Given this list of marker genes IRF4, DPP4, C12orf56, GAB3, FURIN, TCP1, SEC23B, RGS1 (regulator of G protein signaling 1), BATF, NCOA3, SPINT2, VDR, IMMT, RRAGD, RPS6KB2, RAB30 (NCBI Gene Id 27314), CYTH1, TSPAN5, BHLHE40, HERC1, MIR21, EOMES, MKRN1, LRRC59, LIMA1, CTLA4, IL9, ATXN1, SMARCAL1, ETNK1, TBC1D1, TESPA1, ABHD4, STK4, FCHSD2, CD5, ANKRD44, RASL11A, SEMA4D, NIPAL2, DMAC2, HPGD, IL2RA, KPNA6, RAB19, FGFR1OP2, GAB2, HSPH1, CREB3, TIAM1, TRAFD1, PGM3, NFKBIZ, IL5, HSPA13, AP4B1, RASGRP3, RGS16, MAPK1, RNF125, IL13, BCL2, EEIG2, TXNDC16, MEOX1, SLC9A7, STK17B, SSNA1, H2BC21, ADAM19, LRIG1, RASAL3, PLXDC1, XPOT, PTPN9, FAM98A, DARS1, SYTL3, HIPK1, GPCPD1, MAN2A2, ASAP1, CD69, PRPF38B, ETS1, GIT2, SNORA52, DHRS3, ITK, CERS6, GNG2, BTG1, NABP1, TMEM71, KRT1, EAF1, NIT1, CD200R1, IER5, H2AJ, ELL2, GFI1, FYN, RASSF5, TBC1D13, CYLD, IKZF2, ACTN4, TBC1D20, NBEAL2 (NCBI Gene Id 23218, neurobeachin like 2), RAB27B, FAM50A, H2AC21, CYC1, TNF, TNFSF8, RNF168, CDH1, CASP3, SGSH, GNPDA1, LRRC32, DUSP4, PHF20L1, IKZF4, LPAL2, PRKCQ, CISH, SMAP2, CSF1, CSRP1, MGAT2 (alpha-1,6-mannosyl-glycoprotein 2-beta-N-acetylglucosaminyltransferase), YWHAQP8, DIPK1A, SEMA5A, ARHGAP25, TUT7, LCP2, GLDC, CEP164, RAP1A, BCL6, SLCO3A1, SLC39A8 (solute carrier family 39 member 8), PTPN1, CNKSR2, CD84 (NCBI Gene Id 8832), XBP1, NSMCE1, PGM1, SNORA70E, RASA1, TRIP10, REL, TPD52L2, IL17RB, RRM1, ACD, HIPK2, CD44 (NCBI Gene Id 960), PTGER2, LRFN2, MAP4K1, GPR132, HDAC9, SLC37A3, BCL11B, POLR2E, P4HB, BCL2L1, MAL, ST8SIA4, CXCL13, CAMK2D, CXCR4, UNC13D, ETV3, SOCS1, SLC12A2, GDI1, CD46, PITRM1, NMT1, TIGIT, C12orf76, MRPL35, PTGDR, PECAM1, TNFRSF9, NDFIP2, CDCA7L, EDARADD, PCED1B, SLC26A11, PDE4B, TTC39B (NCBI Gene Id 158219), JOSD1 (NCBI Gene Id 9929), IGSF11, STAT4, here is a description of the gene set: STAT3, an essential transcription factor with pleiotropic functions, plays critical roles in the pathogenesis of autoimmunity. Despite recent data linking STAT3 with inflammatory bowel disease, exactly how it contributes to chronic intestinal inflammation is not known. Using a T cell transfer model of colitis we found that STAT3 expression in T cells was essential for the induction of both colitis and systemic inflammation. STAT3 was critical in modulating the balance of T helper 17 (Th17) and regulatory T (Treg) cells, as well as in promoting CD4+ T cell proliferation. We used chromatin immunoprecipitation and massive parallel sequencing (ChIP-Seq) to define the genome-wide targets of STAT3 in CD4+ T cells. We found that STAT3 bound to multiple genes involved in Th17 cell differentiation, cell activation, proliferation and survival, regulating both expression and epigenetic modifications. Thus, STAT3 orchestrates multiple critical aspects of T cell function in inflammation and homeostasis. Human Gene Set: GSE21670_UNTREATED_VS_TGFB_TREATED_STAT3_KO_CD4_TCELL_DN Genes down-regulated in CD4 T cells with STAT3 knockout: medium versus TGF beta. from publication Durant L, Watford WT, Ramos HL, Laurence A, Vahedi G, Wei L, Takahashi H, Sun HW, Kanno Y, Powrie F, O'Shea JJ (PMID 20493732) studied in species Homo sapiens